Given this list of marker genes AIP, ARNT, ARNT2, HSP90AB1, PTGES3, AHR, here is a description of the gene set: Aryl hydrocarbon receptor signalling species: Homo sapiens Human Gene Set: REACTOME_ARYL_HYDROCARBON_RECEPTOR_SIGNALLING